The following is a description of a gene set: Mouse Gene Set: GOBP_REGULATION_OF_REACTIVE_OXYGEN_SPECIES_BIOSYNTHETIC_PROCESS Any process that modulates the frequency, rate or extent of reactive oxygen species biosynthetic process. studied in species Mus musculus, and this is the list of marker genes: Sphk2, Abcd1, Slc5a3, Pikfyve, Hbp1, Arg2, Sod2, Ncf2, Ins1, Ogt, Alox5, Cyba, Zfp13, Mfn2, Sirt1, Prkn, Rab27a, Ndufc2, Cd36, Ppara, Mpv17l, Slc25a33, Ptgr1, Alox12, Park7 (NCBI Gene Id 57320), Tlr4, Ins2, Il4, Ucp1, Duoxa1, Ctns (cystinosis, nephropathic), Clcn3, Stat3, Grin1, Tlr6, Hvcn1, Abcb7, Adgrb1, Coa8, Ccn6, Nox4, Hdac4, Fyn, Abcd2, Rhoa, Plcg2, Foxo3, Hif1a, Lcn2, Cflar, Adcy10, Hspd1, Duoxa2